Given this list of marker genes Il13, Akap8, Oas3, Abcd1, Pla2g10, Ptpn22, Cd274, Gstp-ps, Ppm1b, Casp3, Fbln1, Igf1, Gba1, Lgr4, Zc3h12a, Spag11a, Lag3, Fxr1, Nr1h4, Ghsr, Mefv, Stat3, Nckap1l, Rel, Socs5, Morc3, Ffar1, Wnt11, Atp2b1, Traf3ip1, Rara, Il23a, Tnfaip3, Ephb2, Nlrp3, Il20rb, Homer2, Erbin, Aqp4, Cd24a, Cactin (cactin, spliceosome C complex subunit), Chid1, Tgfb2, Pdcd4, Rabgef1, Elane, F2, Rnf125 (NCBI Gene Id 67664), Tigit, Hdac9, Nlrc3, Sh2d1b1, Errfi1, Lilrb4b, Ddit3, Angpt1, Ptprs, Bank1, Gimap3, Oas1a, Muc16, Tgfb1, Tnfrsf21, Mc1r, Tsku, Nploc4, Lilra5, Nptn, N4bp1, Gstp3, Nav3, Foxj1, C1qbp, Tlr4, Oas1h, Bpi, Oas1b, Traip, Lilrb4a, Il22, Pglyrp4, Nfkb1 (NCBI Gene Id 18033), Fgfr4, Foxp3, Oas1f, Cuedc2, Rnf128, Laptm4b, Irgm1, Adcy7, Ptpn11, Serpinb1b, Il1rl1, Anxa1, Slc11a1 (solute carrier family 11 (proton-coupled divalent metal ion transporters), member 1), Chrna7, Trim30a, Il22ra1, Slc2a10, Nlrx1, Ppara, Trem2, Flt1, Tgfb3, Arg2, Cx3cr1, Il36rn, Klf4, Map2k5, Tia1, Pdcd1lg2, Laptm5, Btk, Cryba1, Ido1 (indoleamine 2,3-dioxygenase 1), Atg5, Slc37a4, Ubr5, Twsg1, Jak2, Nlrp12, Abcd2, Ptger4, Il12b, Arg1, Flt3, Fgfr1, Cx3cl1 (C-X3-C motif chemokine ligand 1), Ghrl, Epx, Gata6, Tyrobp, Extl3, Cd200 (NCBI Gene Id 17470), Oas1e, Zfpm1, Hgf, Cd2ap, Cidea, C1qtnf3, Fcgr2b, Homer3, Anxa4, Bcl3, Pibf1, Il23r, Il6, Tlr6, Xaf1, Axl, Gpnmb (glycoprotein (transmembrane) nmb), Clec4a3, Tbx21, Ccr7, Yy1 (NCBI Gene Id 22632), Zfp683, Ezh2, Ssc5d, Ptpn6, Hfe, Atg9a, Oas1g, Klhl22, Elf4, Twist1, Gbp4, Mul1, Nutf2-ps1, Tnfrsf4, Peli3 (NCBI Gene Id 77713), Vsig4, Jak3, Cul3, Cptp, Cd59a, Mertk, Pparg, Syt11, Irgm2, Dicer1, Ezr, Furin, Tlr2, Igtp, Irak3, Ufd1, Tnfsf4, Ilrun, Spink7, Arrb1, Btn2a2, Pomc, Inpp5d, Sftpd, Acp5, Lbp, Appl2, Srgn, Rgcc, Tspo, Vsir, Hmgb1, Trib2, Git1, Serpinb1c, Slamf1, Sars1, Met, Scgb1a1, Rbx1, Cd96, Lef1, Rad21, Ltf, Tnfrsf1a, Prg4, Trim27, Il27ra, Ffar4, Kat5, Bst2, Tusc2, Cd83, Gimap5, Il4, Klf2, Epha2, Pglyrp1, Lgals9, Rbx1-ps, Bcl6, Prg2, Csk, Atg12, Ndrg2, Cd84, Ppp1r11, Pml, Ticam2 (NCBI Gene Id 225471), Hmox1, Ifng, Prnp, Nfkbil1, Kat8, Zfp36, Ceacam1, Pglyrp3, Qki, Acod1, Twist2, Apoa1, Dll1, Prkca, Smad7, Clec4a4, Apoa2, Otud7b, Siglec1, Relb, Nmb, Ifnb1, F2rl1, Cd200r1, Cd276, Mir301, Clec4a2, Xcl1, Ndfip1, Fn1, Otud5, Reg3g, Hdac3, C5ar2, Hsf1, Nmi, Ptprc (protein tyrosine phosphatase receptor type C), Sirpa, Tlr8, Pycard, Mir98, Sigirr, Arrb2, Sirt1, Nlrp6, Gbp7, Oas1c, Cd34, Ager, Gstp1, Ddx56 (NCBI Gene Id 68057), Il12a, Rac1, Gpr174, Il10, Serpinb1a, Parp1 (poly (ADP-ribose) polymerase family, member 1), Oas1d (NCBI Gene Id 97256), Il1r2, Thbs1, Lrrc32, Crebbp, Suz12, Banf1, Selenos, Havcr2, Tnf, Gas6, Cmklr1, Gpatch3, Macir, Gata3, Gpr18, Hdac7, Apod, Pglyrp2, Nod2, Mapkbp1, Dhx58, Nmbr, Nutf2, Adipoq, Il33, Gstp2, Inhbb, here is a description of the gene set: Any process that stops, prevents, or reduces the rate of production of a cytokine. studied in species Mus musculus Mouse Gene Set: GOBP_NEGATIVE_REGULATION_OF_CYTOKINE_PRODUCTION